The following is a description of a gene set: from publication Yevshin I, Sharipov R, Kolmykov S, Kondrakhin Y, Kolpakov F (PMID 30445619) Human Gene Set: SIRT3_TARGET_GENES studied in species Homo sapiens Genes containing one or more binding sites for (SIRT3) in their promoter regions (TSS -1000,+100 bp) as identified by GTRD version 20.06 ChIP-seq harmonization., and this is the list of marker genes: LINC00662 (long intergenic non-protein coding RNA 662), ENSG00000199856, RN7SKP293, NSL1, MIR6882, TAFA2, MIR1299, PABPC1 (NCBI Gene Id 26986), POLR3GP2, RGL4, SCNM1, MIR466, SEC61A2, RPL9P3, GPANK1, MIR199A2, MTUS1, GUSBP11, L3MBTL1, CCDC57, TATDN3, PHKG1, NUP98, GPR75 (NCBI Gene Id 10936), SNX11, PPP1R42, RNU6-185P, GAL3ST1, ATP13A3, ATG7, LINC02038, MAP2K1, DNM3OS (NCBI Gene Id 100628315), SNX10, ARHGAP28, RMDN1, AGBL4-AS1, ASAP1, FKBP4, CSNK2B, TFRC, DAB2, INTS9, LINC00578, ILVBL, RNA5SP46, KPNA2P2, GCC2, HMGN1P2, BVES, YWHAZ, WIPF3, MRPL49, TRAJ19, SAMD4A, LINC02724, BCAR1 (NCBI Gene Id 9564), SLF2, MYO1E, NSMF, CHL1-AS1